Given this list of marker genes HEY1, CAV3, FHL2, FKBP1A, BMP10, EGLN1 (NCBI Gene Id 54703), HEY2 (NCBI Gene Id 30830), RBP4, SRF, NKX2-5, TEK, ADAMTS1, OVOL2, TGFBR3 (transforming growth factor beta receptor 3), ADGRG6, here is a description of the gene set: Human Gene Set: GOBP_HEART_TRABECULA_FORMATION species: Homo sapiens The process of creating a trabecula in the heart. A trabecula is a tissue element in the form of a small beam, strut or rod.